The following is a description of a gene set: Any process that stops, prevents, or reduces the frequency, rate, or extent of interleukin-6 production. Human Gene Set: GOBP_NEGATIVE_REGULATION_OF_INTERLEUKIN_6_PRODUCTION species: Homo sapiens, and this is the list of marker genes: IL10, ARRB1, BPI, SLAMF1, MIR146A, NLRP12, ZC3H12A, C5AR2, CD200R1, IL27RA, SOCS5, MIR181A2, C1QTNF3, IL36RN, NMBR, MIR338, MIR98, NLRC3, TNFAIP3, MIR206, MIR149, NMB, HGF, TLR4, MIR204 (NCBI Gene Id 406987), GHSR, ORM1, MIR105-1 (microRNA 105-1), MIR766 (NCBI Gene Id 768218), MIR140 (NCBI Gene Id 406932), PTPN22, FOXP3, PTPN6, MIR195, MIR26A1, CX3CL1, GAS6, NLRX1, MIR101-1, GHRL, MIR132, KLF2, SYT11, RABGEF1, MIR19A, GBA1 (glucosylceramidase beta 1), NCKAP1L, IL37, INPP5D, SIRPA, BANK1 (B cell scaffold protein with ankyrin repeats 1), MIR6869, NR1H4, MIR708, TNF, MIR217, CSK, IRAK3, FOXJ1, MIR365A, ELF4, ARRB2, MIR19B1, CD200, SELENOS, LILRB4, HAVCR2